The following is a description of a gene set: Reactome Pathway: TFAP2 (AP-2) family regulates transcription of growth factors and their receptors species: Homo sapiens TFAP2A and TFAP2C directly stimulate transcription of the estrogen receptor ESR1 gene. TFAP2A expression correlates with ESR1 expression in breast cancer, and TFAP2C is frequently overexpressed in estrogen-positive breast cancer and endometrial cancer (deConinck et al. 1995, Turner et al. 1998). TFAP2A, TFAP2C, as well as TFAP2B can directly stimulate the expression of ERBB2, another important breast cancer gene. Association of TFAP2A with the YY1 transcription factor significantly increases the ERBB2 transcription rate. In addition to ERBB2, the expression of another receptor tyrosine kinase, KIT, is also stimulated by TFAP2A and TFAP2B, while the expression of the VEGF receptor tyrosine kinase ligand VEGFA is repressed by TFAP2A. TFAP2A stimulates transcription of the transforming growth factor alpha (TGFA) gene. TFAP2C regulates EGFR expression in luminal breast cancer (De Andrade et al. 2016). In placenta, TFAP2A and TFAP2C directly stimulate transcription of both subunits of the human chorionic gonadotropin, CGA and CGB. part of: Transcriptional regulation by the AP-2 (TFAP2) family of transcription factors, and this is the list of marker genes: TFAP2A, ERBB2, TFAP2B, CGA, YY1, ATAD2, KIT, TFAP2C, CGB3, ESR1, VEGFA, TGFA, EGFR